Given this list of marker genes Ago1, Ago4, Tnrc6a, Ago2, Ago3, Tnrc6b, here is a description of the gene set: studied in species Mus musculus Mouse Gene Set: REACTOME_POST_TRANSCRIPTIONAL_SILENCING_BY_SMALL_RNAS Post-transcriptional silencing by small RNAs